Given this list of marker genes Unc13d, Avl9 (NCBI Gene Id 78937), Abhd17b, Sorcs2, Slc9a5, Tpcn1, Ackr3, Pacsin2, Plekhb2, Bace1, Clcn3, Slc30a10, Tmub1, Inpp5f, Atp13a3, Ehbp1l1, Micall1, Abhd17a, Gripap1, Stx8, Ndrg1, Fchsd1, Atg9a, Snx18, Tubgcp4, Vamp8, Tfrc, Pla2g3, Lmtk2, Rab4a, Snf8, Amotl2, Rap2c, Arf6, Abcg1, Relch, Tnik, Uts2r, Pigr, Rab14, Grip1, Aqp2, Zfyve27, Stx12, Sgk3, Inhca, Rab4b, Vps33b, Rab11fip4, Mcoln2, Meltf, Mctp1, Abcb11, Ap1g1, Vps50, Gper1, Cd22, Ank2, Ran, Tbc1d14, Sorl1, Rnf11, Pla2g5, App, Rep15, Pheta2, Ackr2, Tubg1, Nsg1, Gpr161, Tmem230, Vps13b, Slc9a7, Vps16, Ntrk1, Syt11, Ehd4, Rab8a, Washc1, Rabgef1, Slc31a2, Arfgef2, Rabep1, Syt5 (synaptotagmin V), Stx6, Rac1, Hfe, Snx27, Dennd6b, Slc36a2, Eea1, Agtr1a, Nisch, Acap1, Slc9a6, Atg9b, Akap5, Scamp3, Rab29, Dync1li1, Rab11fip5, Atp11c, Mlc1, Or2a7, Rab11a, Atp11b, Plekhj1, Gga3, Fig4, Dennd2b, Eipr1, Lamp5, Pheta1, Tnf, Vamp3, Ltf, Rab17, Slc26a7, Micall2, Plekha3, Ehd2, Commd1, Lztr1, Rassf9, Vps26b, Rab13, Rab10, Entr1, Slc9a9, Bok (BCL2-related ovarian killer), Vps51, Bloc1s2, Slc31a1, Tuba1a, Zdhhc2, Pdlim4, Vipas39, Atp13a4, Vps53, Rap2a, Tbc1d17, Slc9b2, Rffl, Slc1a1, Ehd3, Cd274, Cftr, Kcnk1, Rab11fip3, Atp11a, Optn, Neu3, Itgb1, Slc11a2, Ldlrap1, Atp9a, Gria1, Fchsd2, Arhgap44, Dync1i1, Cmtm6, Slc39a4, Myo5a, Fzd7, Rab25, Dnm2, Slc9a3, Ehd1, Itsn1, Dennd6a, Scamp1, Clcn4, Cln3, Mtmr4, Ackr4, Rap2b, Ackr1, Trf, Clip3 (CAP-GLY domain containing linker protein 3), Rab12, Rab11fip1, Insr, Stx7, Gnas, Rab11b, Inpp4a, Ldlr, Fcgr2b, Ap3m1, Rab11fip2, Scamp4, St8sia2, Wipf3, Myo5b, Baiap3, Vps52, Vti1b, Pank1, 2610528J11Rik, Entrep1, Rab5a, Scamp2, Abhd17c, Tpp1, Scamp5, Tbc1d12, here is a description of the gene set: An organelle consisting of a network of tubules that functions in targeting molecules, such as receptors transporters and lipids, to the plasma membrane. Mouse Gene Set: GOCC_RECYCLING_ENDOSOME studied in species Mus musculus